The following is a description of a gene set: Human Gene Set: HE_LIM_SUN_FETAL_LUNG_C2_CXCL9_POS_MACROPHAGE_CELL from publication He P, Lim K, Sun D, Pett JP, Jeng Q, Polanski K, Dong Z, Bolt L, Richardson L, Mamanova L, Dabrowska M, Wilbrey-Clark A, Madissoon E, Tuong ZK, Dann E, Suo C, Goh I, Yoshida M, Nikolić MZ, Janes SM, He X, Barker RA, Teichmann SA, Marioni JC, Meyer KB, Rawlins EL (PMID 36493756) CXCL9+ Mφ species: Homo sapiens, and this is the list of marker genes: EPSTI1, VCAM1, GBP3, IL27, CD274, APOL6, IL15RA, DTX3L, P2RX7, TAP2, SAMD9L, PARAIL, SLAMF7, C15orf48, FBXO6, CLEC4E, BIRC3, CD38, TRAF1, ACSL1, IFIT2, FNDC3B, CUL1, IFIH1, CD40, PIM1, FFAR2, LAMP3, XKR8, JMJD4, TRIM69, FAS, GPR84, LINC00937 (NCBI Gene Id 389634), TAP1, HIVEP2, IL15, LGALS3BP, ARAP2, TRAF3, STAT1, SRC, GBP1, APOBEC3A (NCBI Gene Id 91577), LIMK2, ETV7, GBP5, CCL8, NFE2L3, STEAP4, IFITM1, SERPING1 (NCBI Gene Id 710), DRAM1, C21orf91, LINC01678, TIFAB, VPS9D1, EBI3, IL4I1 (NCBI Gene Id 259307), TRAFD1, CASP5, RNF19B, KSR1, GGT5, APOL2 (NCBI Gene Id 23780), PARP9, CXCL11, CCL19, ISG20, IDO1, OAS3, MX1, IRF9, CXCL9, CAMK2D, NECTIN2, METTL1, IFIT3, IL32, HCAR3, P2RY14, STAMBPL1, HIVEP3, MIR503HG, GBP2, NLRC5, IFI35, GBP4, TMEM140, VAMP5, USP12, SGTB, HLA-F, TBC1D2B, GCH1, DNAJC14, PATL2, APOL3, NBN, XAF1, IKBKE, SLC31A2, PTGIR, SLAMF8, SOCS1, PRR5L, MT2A, PLAAT4, OASL, FAM241A, SECTM1, BATF, UST, SERPINB9, IFI6, TIFA, ANKRD22, FCGR1BP, TNFRSF4, CD80, PARP12 (poly(ADP-ribose) polymerase family member 12), OAS2, SLC2A6, HAPLN3, RAPGEF2, CXCL10, IL1RN